The following is a description of a gene set: from publication Cui S, Li C, Ema M, Weinstein J, Quaggin SE (PMID 16207825) Mouse mutations have provided tremendous insights into the molecular basis of renal and glomerular development. However, genes often play important roles during multiple stages of nephrogenesis, making it difficult to determine the role of a gene in a specific cell lineage such as the podocyte. Conditional gene targeting and chimeric analysis are two possible approaches to dissect the function of genes in specific cell populations. However, these are labor-intensive and costly and require the generation, validation, and analysis of additional transgenic lines. For overcoming these shortcomings and, specifically, for studying the role of gene function in developing glomeruli, a technique to isolate and purify glomeruli from murine embryos was developed. Combined with gene expression profiling, this method was used to identify differentially expressed genes in glomeruli from Pod1 knockout (KO) mice that die in the perinatal period with multiple renal defects. Glomeruli from early developing stages (late S-shape/early capillary loop) onward can be isolated successfully from wild-type and KO kidneys at 18.5 d postcoitus, and RNA can readily be obtained and used for genome-wide microarray analysis. With this approach, genes that are differently expressed between glomeruli from Pod1 KO and wild-type mice were identified, including a four-fold reduction of alpha 8 integrin mRNA in glomeruli from Pod1 KO mice that was confirmed by immunostaining. This procedure may be adapted to any transgenic strain, providing a rapid and efficient method to dissect the function of specific genes in glomerular development. Mouse Gene Set: CUI_TCF21_TARGETS_UP Genes most strongly up-regulated in kidney glomeruli isolated from TCF21 knockout mice. species: Mus musculus, and this is the list of marker genes: Lum, Penk, Cyp7b1, Lbp, Mdk, Stard10, Cadm1, Islr, Ptn (pleiotrophin), Hmmr, Cfh, Igfbp2, Dcn, Fap, Meg3, Vcan, Cdh6, Rbp1, Homer2, Cdkn1b, Hjurp, Col6a1, Lhfpl2, Serpinf1, Cldn9, Ncam1, Epha4, Hdac11, Phgdh, Col6a2, Igdcc4, Col8a2, Sox11, Col3a1, Ccnd2, Cldn6